The following is a description of a gene set: Human Gene Set: HP_ABNORMALITY_OF_SKIN_ADNEXA_PHYSIOLOGY Abnormality of skin adnexa physiology species: Homo sapiens Any functional anomaly of the skin adnexa (skin appendages), which are specialized skin structures located within the dermis and focally within the subcutaneous fatty tissue, comprising three histologically distinct structures: (1) the pilosebaceous unit (hair follicle and sebaceous glands); (2) the eccrine sweat glands; and (3) the apocrine glands., and this is the list of marker genes: ALPK1 (alpha kinase 1), BCL10, SLCO2A1 (NCBI Gene Id 6578), SDHC, CLCN6, KCTD1, RSPO1, KIF1A, FBXO11, TRANK1, DKC1, CTSB, THPO, WNT10A, FH, EDARADD, SOX5, GLA, ALOX12B, MOG, MADD, PARN (NCBI Gene Id 5073), COQ2, COL11A1, EPAS1, EDAR, DDC, ALOXE3, PKP1, SLC12A3, HNF1A, SLC1A3, SLC18A2, ATL1 (atlastin GTPase 1), MAP2K2, FGFR2, HNRNPK, NECTIN1, SERPINB7, HCRT, RIPK4, TNFSF4, RETREG1, SHANK3, CDKN2A, FLG, ITPR2, SLC39A14, KRT6A, TRIP4, VHL, BRAF, CLCF1 (NCBI Gene Id 23529), COG6, LIFR, PROKR2, KRT6B, GMPPA, AQP5, MEN1, SUCLA2, RET, JAK2, DSG1, NOP10, ST14, ZFHX2, CACNA1S, H19, ERCC4, IGHMBP2, PNPLA1, ZEB2, PTPN22, ATL3, GRB10, CFTR, CAMK2B, SUCLG1, SCN9A, POLA1, KRT74, MAP2K1, IKBKG, CTC1, P2RY11, ROGDI, CERS3, KIF1B, SPRED2, HLA-DQB1, NGLY1, KRT14 (keratin 14), SPTLC2, ELP1, ZNF365, KDF1, FLRT1, RAF1 (NCBI Gene Id 5894), IGF2, SLC25A11, ABCA12, NPM1, ABCC8, RTEL1, OTX2, CSTB, TINF2 (TERF1 interacting nuclear factor 2), DPP9, CNBP, UCP2, GJB6, SCN11A, PHOX2B, CDH23, KRT1, CLCNKB, CTSH, MPL, MALT1, HNF4A, TMEM127, SULT2B1, EDA, SPR, HESX1, FOXP1, SDHD, ERCC8, SOX3, STS, ATP1A2, PAX9, TERT, FAM111B, FGFR1, SOX2, NTRK1, SOX10, CCND1, P4HA2, HLA-DRB1, RYR1, GJB2, COL17A1, ALDOB, KCNJ11, KCNJ18, HMBS, EDA2R, MBTPS2, TAT, ARX, CUL4B, KRT5, GNA14, CDH3, HPGD, TYMS, ARNT2, ELOVL4, KRT17, TRAF6, ZNRF3, NLRP3, ADAMTS15, SDHAF2 (NCBI Gene Id 54949), CTNNB1, NF1, MAX, USB1, KCNA1, PRNP, GABRA3, SLURP1, ALK, KLHL7, TRPV3, ATP1A3, HINT1, LMNB1, AIP, BIRC3, ERCC6 (NCBI Gene Id 282965), GHR, KLC2, BOLA3, HLA-B, PRKAR1A, CACNA1A, NFKBIA (NFKB inhibitor alpha), CRLF1, MDH2, SHQ1, PRDM12, CASK, SLC13A5 (NCBI Gene Id 284111), KRT9, WNK1, TERC, PLAA, CTNS, BCS1L, SPTLC1, TGM1, CST6, NGF, CDSN, KRT16, CLDN10, GPR101, FUCA1, DST (NCBI Gene Id 80105), STIM1, TP63, JUP, DLST, TSPEAR, COL6A1, DNMT3A, YY1, HRAS, SDHA, SDR9C7, NIPAL4, TP53, NHP2, PERP, SDHB, LPAR6, NRAS, ADAT3, SMARCAD1, WRAP53, HEXB, ALX4, LAMB3